The following is a description of a gene set: Human Gene Set: MIR769_5P from publication Chen Y, Wang X (PMID 31504780) species: Homo sapiens Genes predicted to be targets of miRBase v22 microRNA hsa-miR-769-5p in miRDB v6.0 with MirTarget v4 prediction scores > 80 (high confidence targets)., and this is the list of marker genes: PRR29, LYPLAL1, SYTL2, CERCAM, POU4F1, MAPK1, PSD2, LRP12, C1QTNF1, TBC1D20, SSNA1, FAXDC2, NFKBID, ZNF415, FBXO21, WDR37, PARD6B, FBXL7, TET3 (NCBI Gene Id 23298), ITSN1, AKAP1, TFAM, SET, LRRTM2, CUL5, TFAP4, SS18L1 (SS18L1 subunit of BAF chromatin remodeling complex), OPRM1, WFDC11, TDRD6, WDFY3, BPNT1, ACKR2, P2RY1, CPEB1, RGS7BP, BEAN1, SPAST, SYP, MRPS16 (mitochondrial ribosomal protein S16), UPF3B, SMAD2, PDCD4, PLEKHA1, AKT3, PRKAA1, HS3ST4, STK35